The following is a description of a gene set: studied in species Mus musculus Mouse Gene Set: GOBP_REGULATION_OF_THE_FORCE_OF_HEART_CONTRACTION_BY_CHEMICAL_SIGNAL The regulation of the force of heart muscle contraction mediated by chemical signaling, hormonal, autocrine or paracrine., and this is the list of marker genes: Adrb1 (adrenergic receptor, beta 1), Adrb2, Grk2, Adra1a, Nos3, Cav1, Adra1b